Given this list of marker genes EVA1A, HNRNPR, GNB1, VPS4B, KHNYN, MTUS1, ZFC3H1, FNIP1, HNRNPH1, C6orf120, CADM2, CNOT4, HMGA2, UBE2D2, AQP9, DYRK1A, FGFR1OP2, OGT, CATSPER2, PPP1CC, MAP4, PAPPA (NCBI Gene Id 5069), OSBPL8, KPNA1, E2F5, CTDSPL2, WNT5A, PHF20, CUL2, MAF, ADNP (NCBI Gene Id 256440), PKNOX2, SOCS5, PPM1E, BRCA1, TCF12, HNRNPA0, KAT7, TRIB2, UBE2A, ATP2B1, CAMK2G, RNF19A, FOXN3, SCARA5, IL20, MARCHF7, WAC, SALL1, PLAGL2, FBXL16, CIC, UBE2D3, COPS2, HDHD2, RAB5B, GRM7, EVI5, PCNA, DOCK1, RNF11, CHST9, here is a description of the gene set: species: Homo sapiens Human Gene Set: ATAACCT_MIR154 Genes having at least one occurence of the motif ATAACCT in their 3' untranslated region. The motif represents putative target (that is, seed match) of human mature miRNA hsa-miR-154 (v7.1 miRBase).